Given this list of marker genes SLC44A4, BCHE, ACHE, COLQ, FSHR, SLC5A7, CHAT, here is a description of the gene set: The chemical reactions and pathways involving an acetate ester, any carboxylic ester where the carboxylic acid component is acetic acid. studied in species Homo sapiens Human Gene Set: GOBP_ACETATE_ESTER_METABOLIC_PROCESS